The following is a description of a gene set: IRAK-4 is an essential component of the signal transduction complex downstream of the IL-1- and Toll-like receptors. Though regarded as the first kinase in the signaling cascade, the role of IRAK-4 kinase activity versus its scaffold function is still controversial. In order to investigate the role of IRAK-4 kinase function in vivo, ‘knock-in’ mice were generated by replacing the wild type IRAK-4 gene with a mutant gene encoding kinase deficient IRAK-4 protein (IRAK-4 KD). Analysis of bone marrow macrophages obtained from WT and IRAK-4 KD mice with a number of experimental techniques demonstrated that the IRAK-4 KD cells greatly lack responsiveness to stimulation with the Toll-like receptor 4 (TLR4) agonist LPS. One of the techniques used, microarray analysis, identified IRAK-4 kinase-dependent LPS response genes and revealed that the induction of LPS-responsive mRNAs was largely ablated in IRAK-4 KD cells. In summary, our results suggest that IRAK-4 kinase activity plays a critical role in TLR4-mediated induction of inflammatory responses. species: Homo sapiens Genes up-regulated in comparison of untreated macrophages from IRAK4 deficient mice at 4 h versus those treated with LPS (TLR4 agonist) at 1 h. from publication Koziczak-Holbro M, Glück A, Tschopp C, Mathison JC, Gram H (PMID 18266302) Human Gene Set: GSE9037_CTRL_VS_LPS_1H_STIM_IRAK4_KO_BMDM_UP, and this is the list of marker genes: CDK2, DTX4, CCDC28A, ALG1, USP31, CACUL1, GPANK1, B3GNT2, BAZ2A, PDE3A, SCRN3, DRAM2, AGO4, CD2, ZNF32, GLS, MYCT1, BMP2K, MAP3K1, RALGAPB, SH3KBP1, COMMD7, GTF3C4, ZNF710, PFKFB3, ADA, TMEM127, GPR137B, DMAC2, SSNA1, COL19A1, MTIF3, NBR1, RCSD1, RAB21, SYVN1, EZH1, CYBA, TRIM32, RAP2A, WDR24, ABCG1, TRIM3, GALC, FZD7, ZNF623, NSMCE2, KHDC3L, TXNL4B, TPP1, CXXC1, ANKRD37, GPAM, TTC9C, GRIA1, TPRA1, CD200R1, LRRTM4 (NCBI Gene Id 80059), TMEM178A, IDH3B, NHLRC3, ATG13 (NCBI Gene Id 9776), RWDD2A, KIAA1217, SLC12A3, SDS, NFAM1, TMEM42, VPS37A, MTUS1, CEBPD, SSX5, MED22, ERI2, KTI12, ZBTB33, DCTD, RPL13A, HLX, ZNF236, B3GNT8 (UDP-GlcNAc:betaGal beta-1,3-N-acetylglucosaminyltransferase 8), ZNF251, TMF1, ANGPTL7, UFD1, ZNF764, OR51B2, SWAP70, COL4A6, KNOP1, RCOR3, DCUN1D2, DUSP6, STK38, HRAS, XRCC1, TMBIM1, GPHN, CPOX, CD27, RNF185, PIK3CD, RBM42, TSEN54, DIO2, ITGB5, PLSCR4, ATP13A2, NDUFS2, GLCE, OSBPL9, GPR146, GABPB2, METTL18, ACOT8, UBFD1 (NCBI Gene Id 56061), PDCD6, SMPD4, MIEN1, CAPN15, BAHD1, HSPA4L, CCL22, ZNF664, FBXO45, TMEM208, RANBP10, SIRT3, RUFY3, YAE1 (YAE1 maturation factor of ABCE1), KCNMB4, FASTKD5, IRF2BPL, FKBP1B, PPCS, BFAR, HBP1, SCARB2, SNX33, BRF2, CCDC32, FBXO30, PKIB, CENPJ, RAE1, GALNT16, PPM1K, CRBN, RDH13, RASA2, SEMA3E, CD300LB, PURG, TRPM4, SP3 (NCBI Gene Id 6670), COX14, MED20, BLOC1S1, UTP3, AHNAK2 (AHNAK nucleoprotein 2), MDFIC, ADO, SAT1, SLF2, COASY (NCBI Gene Id 80347), DNAL1, DYNC1LI2, ENO4, SH3BP2, FMNL3, RAD50, BCL2L2, MDP1 (NCBI Gene Id 145553), LIN9, ZFC3H1 (NCBI Gene Id 26055), GSKIP, GZF1, CHORDC1, MFSD12, TTL, SREK1IP1, STXBP5, LRCH1, ZBTB9, PLEKHA2, GIPC2, ASPN, HAGH, KDM1A, PLCXD2, SLC30A7 (solute carrier family 30 member 7), H2AC25, TECPR1, LRRC58, TBC1D9, FAM241A, INSR, ENSA, TCTN3, NRK